Given this list of marker genes Hcls1, Parp1, Uaca, Zpr1, Dmap1, Hdac3, Cdk5rap3, Akt1, Flna, Brca1, Trim28, Mapk14, Psen1 (NCBI Gene Id 19164), Mavs, Smo, Limk2, Gper1, Ect2, Dtx3l, Parp9, Zc3h12a, Xbp1, Crebbp (CREB binding protein), Ptpn22, Nutf2 (nuclear transport factor 2), Ngfr, Cdk1, Ifng, Hsp90aa1, Mepce, Bag3, Nmd3, Hyal2, Lep, Ppp3cb, Jak1, Ran, Bmp4, Prkcq, Ins2, Hsp90ab1, Akap5, Tyk2, Jak2, Trim8, Pinx1, Cacnb4, Ogt, Tfrc, Ep300, Tesk1, Prkd1, Efcab7, Nutf2-ps1, Mapk1, Mcrs1, Npm1, Pik3r1, Jup, Hnrnpm, Edn1, Tardbp, Tek, Tert, Fermt2, Ptgs2, Larp7-ps, Gli3, Chp2, Cdkn2a, Shh, Ins1, Cdh1, Larp7 (La ribonucleoprotein 7, transcriptional regulator), Tgfb2, Sesn2, Tpr, Fyn, Pik3r2, Yap1, Park7, F2, Src, Ipo5, Glis2, Stk11, Il6, Prkcd, Rbm22, Zic1, Card10, Wwtr1, Ipo7, Eif2ak3, Ptpn5, Cav2, Tgfb1, Ubr5, Ormdl3, Cd2ap, Tcf7l2, Lamtor5, Tnfrsf1a, here is a description of the gene set: Mouse Gene Set: GOBP_POSITIVE_REGULATION_OF_PROTEIN_LOCALIZATION_TO_NUCLEUS studied in species Mus musculus Any process that activates or increases the frequency, rate or extent of protein localization to nucleus.